Given this list of marker genes KRT6B, KRT26, BBLN, KRT83, TCHH, KRT76, NEFM, KRT34, KRT28, KRT78, KRT17, KRT77, KRT2, KRT10 (keratin 10), KRT24, KRT85, KRT5, PLEC, KRT80 (NCBI Gene Id 144501), KRT14, NEFL, SHH, KRT72, KRT20, KRT9, KRT84, KRT4, KRT74, KRT25, KRT38, PRPH, KRT3, KRT40, KRT33A, KRT19, DSP, BFSP1, DNAJB6 (DnaJ heat shock protein family (Hsp40) member B6), KRT75, KRT16, KRT6A, KRT13, KRT71, KRT82, KRT81, KLHL24, EPPK1, KRT23, KRT79, MTM1, DES, KRT39, KRT1, KRT37, KRT33B, KRT35, KRT6C, KRT36, KRT73 (NCBI Gene Id 319101), PKP1, AGFG1, GFAP, KRT15, VIM, PKP2, AGFG2, INA (NCBI Gene Id 9118), KRT27, KRT31, KRT86 (NCBI Gene Id 650428), KRT32, KRT12, NEFH, KRT7, BFSP2, here is a description of the gene set: Control of the spatial distribution of intermediate filaments; includes organizing filaments into meshworks, bundles, or other structures, as by cross-linking. species: Homo sapiens Human Gene Set: GOBP_INTERMEDIATE_FILAMENT_ORGANIZATION